The following is a description of a gene set: Human Gene Set: GOBP_DOUBLE_STRAND_BREAK_REPAIR_VIA_NONHOMOLOGOUS_END_JOINING studied in species Homo sapiens The repair of a double-strand break in DNA in which the two broken ends are rejoined with little or no sequence complementarity. Information at the DNA ends may be lost due to the modification of broken DNA ends. This term covers instances of separate pathways, called classical (or canonical) and alternative nonhomologous end joining (C-NHEJ and A-NHEJ). These in turn may further branch into sub-pathways, but evidence is still unclear., and this is the list of marker genes: ERCC4, FH, AUNIP, KDM4D, SMC5, IFFO1, POLA1 (NCBI Gene Id 5422), ASTE1, ERCC8, ACTR2 (actin related protein 2), HSF1, LIG3 (NCBI Gene Id 3980), KMT5C, KMT5B, ATP23, TP53BP1, SHLD1, NUDT16L1, MRNIP, UVRAG, SMCHD1, APLF, NSMCE2, CYREN, PARP3, USP51, POT1, PLK1 (polo like kinase 1), DCLRE1B, KDM2A, RIF1, TOPBP1, TOP2B, ATM, MLH1, HMGB2, XRCC1, NHEJ1 (non-homologous end joining factor 1), ERCC6, POLB, DNTT, NBN, PAXX, LIG4, PNKP, POLQ, POLL, HMGA2, NSD2, SMARCAL1, DEK (DEK proto-oncogene), POLM (NCBI Gene Id 27434), HMCES, RHNO1, MRE11, XRCC6, DCLRE1A, SHLD2, HMGB1, DCLRE1C, SETMAR, RNF8, PRKDC, SHLD3, ERCC1, WAS, WRAP53, TFIP11, XRCC5, XRCC4, ZBTB7A, RNF168, HELQ, PRPF19, PSMD14, MAD2L2, ERCC6L2